Given this list of marker genes MAPRE2, ADAM9, MMP9, IQSEC1, HBEGF, HAS2, FGF7, ARF6, MAP4K4, FGF10, EPPK1 (epiplakin 1), PTEN (NCBI Gene Id 8037), EPB41L4B, MTOR, here is a description of the gene set: studied in species Homo sapiens Human Gene Set: GOBP_REGULATION_OF_KERATINOCYTE_MIGRATION Any process that modulates the frequency, rate or extent of keratinocyte migration.